The following is a description of a gene set: Human Gene Set: CREIGHTON_AKT1_SIGNALING_VIA_MTOR_DN Genes in the AKT1 pathway which depend on MTOR, sensitive to RAD001 (everolimus). species: Homo sapiens from publication Creighton CJ (PMID 17213801) The Akt pathway is commonly deregulated in many cancers. Clinical trials are currently underway to test the effectiveness of breast cancer treatment by inhibition of various Akt pathway intermediates. A set of genes induced by Akt in a transgenic mouse model, a subset of which were sensitive to mammalian target of rapamycin (mTOR) inhibitor RAD001, was examined in five public gene expression profile data sets of clinical breast tumor specimens (representing >1000 different samples in all). In each of the clinical data sets, the Akt mouse model genes as a group were significantly overexpressed in human tumors having high levels of AKT1 mRNA. The subset of genes both upregulated by Akt and dependent on mTOR activity were associated with estrogen receptor-negative status, higher grade, increasing tumor size and poor prognosis in multiple patient cohorts; these associations were either not present or not as strong for the Akt-induced, mTOR-independent genes or for AKT1 expression alone. The genes shown here to be relevant to Akt-mTOR both experimentally and pathologically have the potential for use in a molecular diagnostic to determine which patients should receive mTOR antagonist treatment., and this is the list of marker genes: PPP2R1A, MIF, GPI, ATP6AP1, PFKL, GOT1, TUBB4B, TSPAN1, DHCR7, ATP6V0B, TNFRSF12A, RGL2, MRPS7, CIB1, YWHAB, PPP4C, CTSA, PAFAH1B3, ATP6V0C, ATP6V1F, TOM1, KRT8, ALDOA